Given this list of marker genes OR8H2, TAAR6, OR4F21, OR13C5, OR6C6, OR8D2, OR1G1, GPR151, OR10Q1, OR8B4, OR3A1, OR5P3, OR7D4, OR2L3 (NCBI Gene Id 81468), OR52B4, MTNR1B, OR6T1, OR51T1, OR2M4 (olfactory receptor family 2 subfamily M member 4), OR4D11, F2R, TAS2R19, OR4K5, MAS1L, ADGRB2, OR52E8, MC4R, ADGRD1, SLC39A9, OR52H1, GHSR, TPRA1, OR2C3, OR10A3, OR2M3, FFAR3, P2RY8, OR10C1, GPR149, GPR34, OR2T11 (olfactory receptor family 2 subfamily T member 11), TRHR, MRGPRX4, P2RY2, OR5I1, CHRM3, LPAR4, DRD5, ADGRG3, NMBR, OR2T6, ADRA2A, OR4M2, OR56B2P, ADGRL4, TAS2R7, OR51J1, OR51G1, GPR139, GPR183, LANCL1, RAMP1, GABRB1, OR2T12, OR6N1, SPHK1, OR11L1, OR6J1, OR5AC2, OR8K5, OR2A14, GPR143, CCR1, OR2AJ1, OR10X1, OR2M2, GPR26, TAAR2, OR4D5, GRM7, NPY2R, OR52A4P, CRHR1, OR52N2, TAS2R39, OR6N2, OR2G3, ADRA2C, SORCS3, OR5H14, OR8D1, OR56A3, OR51G2, OR9Q2, OR6F1, ELOVL4, OR7A17 (olfactory receptor family 7 subfamily A member 17), OR6X1, MLNR, OR5H1, OR6C70, ADGRA2, ADGRF2P, OR4D6, GPR3, OR10AC1, OR10T2, VIPR2, OR4L1, OR4A8, OR3A2, OR10H2 (NCBI Gene Id 26538), OR4E2, OR5M9, AGTR1, NLRP6, PTGER2, OR2T10, GPER1, AVPR1A, OR14A2, OR2A5 (olfactory receptor family 2 subfamily A member 5), GPR142, OR8D4, OR5T3, ADRB2, OR5D18, FZD3 (frizzled class receptor 3), OR2A1, OR5AK3P, CHRM1, OR10A6, OR6B2, NMUR2, OR2T33, GPRC6A, GPR157, MRGPRX1, TAS2R50, GPR182, OR1E1, CXCR4, HCAR3, PTGDR2, ADGRB1, GRPR, EDNRA, S1PR2, OR4Q3, OR8B2, SORCS2, OR4C11, OR5A1, GRIK3, OR10W1, OR4A16, OR51H1, ACKR1, OR5AK2, OR11H1, OR2G6, CCR3, PTGER4, AGTR2, OR7G1, DRD2, UTS2R, OR10D3, OR6C1, CASR, OR11H4, OR5AL1, S1PR4, GPR132, OR52L2P (NCBI Gene Id 79274), OPRK1, FBXW7-AS1, GPRC5A, OR2B2, OR4M2B, ADGRG5, OR5H6, OR5B21, GPR65, MRGPRD, CXCR6 (C-X-C motif chemokine receptor 6), OR1N2, OR2AG1, OR5K1, CYSLTR1, PPARG, OR51S1, OR10G4, OR2AT4, OR5C1, OR10A2, MCHR2, GPR20, CHRM2, OR6C3, OR1N1, OR51Q1, ADGRG4, OR10G2, OR6B1 (NCBI Gene Id 393045), LGR4, OR4S1, OR10AD1, OR5B2, SPHK2, OR6K6, FZD5, OXER1, S1PR5, OR5T1, OR11H12, OR52N4, OR11G2, OR51B5, OR4D9, S1PR3, OR12D2, FPR1, OR56A4, GNRHR, OR52E5, ADGRF4, OR4P4, F2RL1, OR5H8, OR2T35, OR10J6P (olfactory receptor family 10 subfamily J member 6 pseudogene), OR52E6, OPN1SW, GNRHR2, GNAT2, MRGPRE, OR13G1, GRM1, ADRB1, HTR5A, ADRA1B, NMUR1, GRM8, GPR135, RAMP2, NPY4R, TAS1R3, GP1BA, OR2A25, RXFP3, OR2C1, P2RY14, GPR25, OR51M1, ADGRE1, OR2AP1, OR5AN1, OR7D2, OR9K2, OR4K15, OR4N4, GPR19, OR1A2, OR56B1, OR10A7, OR11H6, HTR7, OR8G5, FFAR4 (NCBI Gene Id 353126), ADGRE5, OR52I1, OR2A7, OR10G9, GPR174, OR14I1, SMO, OR3A3, ADRA1A, ACKR3, OR1J2, HTR2C, OR4K1, OR1M1, OR4K13, GRM3, OR2AG2, OR5AU1, OR8G3P, OR10P1, GPR85, OR1L8, AGTRAP, CXCR1, PTH1R, OR51D1, OR1K1, OR52E4, P2RY12, TAS2R42, GPR150, OR7C1, OR8B8, VN1R17P, OR52J3, OR1D5, OR4A47, ADGRD2, OR10H5, LPAR1 (NCBI Gene Id 1902), TAS2R3, ACKR2, OR1E3, FZD10, OR10J1, OR1J4, TAS2R38, OR5AC1, OR2A12, GALR3, GPR33, OR7A10, OR52W1, OR51A7 (olfactory receptor family 51 subfamily A member 7), F2RL3, FZD6, OR8G1, OR5T2, APLNR, OR12D1, CELSR2, OR1L4, OR2A2, ADGRL2, CNR2, RXFP4, ADGRG1, GPR179, CHRM5, OR52Z1P, LHCGR, GABBR2, OR2Z1, OR2L13, FPR3, OR52E1, TAAR3P, HCRTR1, P2RY10, GPR63, OR2T7, PRLHR, OR52E2, OR4F29, OR6P1, ADGRF1, OR52M1, HTR2B, GCGR, OR13C4, SSTR3, OR8A1, GPRC5B, GALR1, OR2W3, CCR10, RXFP2, ADORA2A, P2RY11, OR51A4, OR4F3, OR1D4, OR2F1, ADORA1, TAS2R45 (taste 2 receptor member 45), OR4D1, OR4F15, OR51E2, OR11H2, GPR146, OR7A2P, OR10V1, FFAR2, ADORA2B, TAS2R41, LGR5, NPY4R2, GRM4, CXCR3, LGR6, LPAR6 (lysophosphatidic acid receptor 6), GPR176, OR14J1, OR2D3, OR4X2, OR10K1, OR8I2, OR2T4, OR52R1, ADRB3, CCR2, RHO, CELSR3, NPY6R, ADRA2B, SSTR5, OR10G7, HCAR2, HTR1A, LTB4R2, GPR199P, SSTR4, GPR141, OR1B1, CALCR, P2RY4, GPR39 (NCBI Gene Id 2863, G protein-coupled receptor 39), OR1P1, ADGRA1, TACR3, OR5A2, OR8J2, NPY5R, INPP5K, MC5R, OR4Q2 (olfactory receptor family 4 subfamily Q member 2 (gene/pseudogene)), OR52L1, MRGPRX3, OR51B6, OR2F2, OR9A4, DRD1, OR52B6, HTR6, CRCP, OR2J1, OR4A5, OR2K2, OR4D10, GPR161, OR8H3, CCKBR, NPR1, SIGMAR1, ADORA3, OR51V1, TBXA2R, OR5B12, GPR27, FZD2, FZD1, CNR1, OR14C36, OR8B3, OR13C8, HRH3, FZD7 (frizzled class receptor 7), OR6B3, GPR83, OR4K2, OR4F16, OR10S1, HCRTR2, OR8U9, OPRD1, GRM5, OR11A1, GPR31, GPR78, OR1F12P (olfactory receptor family 1 subfamily F member 12, pseudogene), OR8H1, P2RY6, NPY1R, ADGRL3, GPR119, OR10G3, PAX8, OR8S1, NPFFR1, OR1F2P (olfactory receptor family 1 subfamily F member 2 pseudogene), OR9G1, OR9A2, HTR4, MTNR1A, OR8U3, OR5M8, GPR171, HRH4, OR10G6, ADGRE2 (adhesion G protein-coupled receptor E2, NCBI Gene Id 30817), GRM6, OR4C12, TAS2R9, OR6Q1, TAS2R16, HTR1E, OXTR, SUCNR1, OR56A5, GPR35, OR4K17, TAS2R60, OR5P2, OR1S2, OR4F5, OR9A1P, OPN3, NPY, OR6K3, OR2S2, OR1J1, OR2Y1, PTGER1, TAS2R5, OR10J4 (olfactory receptor family 10 subfamily J member 4 (gene/pseudogene)), OR1L1, OR5L1, OR8B12, TAPT1 (transmembrane anterior posterior transformation 1), CCR6, AVPR1B, OR2T2, OR13H1, GPRC5C, P2RY13, OR5H15, PTAFR, OR2A4, CCR8, OR13F1, OR6C68, ADGRG7, MRGPRG, TAAR8, OR2B3, CHRM4, OR10Z1, C3AR1, OR5M10, GPR32, OR51I1, OR13C6P, GLP2R, OR4N5, OR7G2, C5AR2 (NCBI Gene Id 55868, complement C5a receptor 2), OR4A15, TAS2R13, OR2B6, OR52P1, GABBR1, OR4C16, GPR15 (NCBI Gene Id 2838), FSHR, OPN1MW3, CALCRL, OR6A2, GPR75, OR4F4, ADGRG6, OPN1LW, NTSR2, HCAR1, OR2B8P, GPBAR1, OR4A4P, RORB, OR11H7, TAS2R30, GPR22, OR2T27, OR10D4P, OR2H2, CCR7, OR13A1, OR7E24, GPR162, ADGRG2, OR5B17, NPBWR2, OR5V1, GPR153, GRID1, OR4E1, OR8J1, OR9G9, GPR101, OR13C3, OR56B4, OR2T5, TAAR1, GPR84, GPR45 (G protein-coupled receptor 45), OR8U8, OR2L5, GPR156, ADRA1D (NCBI Gene Id 149), PTGDR, OR52N5, OR6V1, HTR2A, OR4C45, OR2A42, SSTR1, CXCR5, GPR50, FZD4, OR7C2, OR6C4, HTR1F, CELSR1, GPRC5D, OPN1MW, NTSR1 (neurotensin receptor 1), OR6C75, MCHR1, GPR158, OR52D1, GALR2, TAS2R43, NPSR1, OR51L1, HRH2, DRD4, TSHR, OR4C15, PDGFRB, CCR5, OR2M7, OR5BS1P (NCBI Gene Id 390313), SCTR, OR2L2, OR5AR1, GPR68, RXFP1, TAS1R1, OR8J3 (NCBI Gene Id 81168), FZD8, OR1A1, OR2W6P, OR52I2, OR8K1, LPAR2, GPR37L1, RAMP3, OR6Y1, CRHR2, MRGPRX2, OR2B11, HPGD, OR7G3, OR2V1, OR10K2, OR10H1, NPR3, OR12D3, FZD9, OR10J5, F2RL2, OR51A2, CCR4, MC3R (melanocortin 3 receptor), OR14K1, OR2T3, GPR87, GPR55, OR4C46, TAS2R31, OR5AP2, OR2V2, OR5K4, OR10H4, KCTD16, HRH1, OR2AE1, OPN4, OR6C76, PTGFR, VIPR1 (vasoactive intestinal peptide receptor 1), OPRM1, GPR62, OR10AG1, OR5M11, OR7A5, OR14L1, BRS3, TAS2R40, OR2T34, GPR32P1, PROKR1, OR51C1P, OR5B3, ADCYAP1R1, LPAR5, VN1R5, OR5M3, OPRL1, OR10H3, OR4F6, TAAR9, BDKRB2 (NCBI Gene Id 624), GPR148, OR10R2, OR5D14, OR10G8, OR5F1, TAS2R1, GRM2, EDNRB, OR6C74, GPR61, OR52K2, CCR9, OR2L8 (NCBI Gene Id 81463), OR2T1, GPR82, OR4C6, OR4C3, OR13C9, PTGIR, GPR17, OR4C13, ADGRF5, VN1R1, OR1L3, OR1F1, NPFFR2, OR1S1, RRH, TAS2R4, OR5H2, OR4F17, OPN1MW2, OR4S2, ACKR4, PTH2R, GAL, GPR42, OR4B1, CXCR2, CMKLR1, ZNF219, OR5K2, GPR37, OR2M5, PDGFRL, OR9G4, TAS2R46, SORCS1, OR5L2, GPR21, OR52A1, OR9Q1, OR14A16, OR2J2, OR5D16, OR4M1 (olfactory receptor family 4 subfamily M member 1), OR2D2, ADGRV1, TAS2R10, TAS1R2, AVPR2, TACR2, OR52B2, SSTR2, GPR18, OR5G3, OR4N2, CX3CR1, TAAR5, ADGRA3, OR13D1, OR2W5P, OR56A1, ADGRL1, TACR1, OR10A5, GPR4, TAS2R14, GPR152, OR2G2, OR1Q1, OR5D13, OR2J3, KISS1R, OR52N1, ADGRF3, OR5AS1, OR8G2P, OR4D2, OR8U1, OR13J1, GPR88, FFAR1, OR51F2, OR1E2, TM2D1, OR5J2, OR6C65, GLP1R, HTR1D, OR6S1, OR5M1, GPR160, OR2W1, GPR52, OR2T29, GPR6, FPR2, OXGR1, CCRL2, P2RY1, MRGPRF, OR52K1, OR4K14, OR51F1, S1PR1, MC1R, OR8K3, OR6M1, XCR1, VN1R3, OPN5, GHRHR, OR51E1, CYSLTR2, CMKLR2, BDKRB1, OR6C2, GIPR, OR10A4, ADGRB3 (NCBI Gene Id 9664), RGR, OR51I2, OR4C5, LPAR3, OR51B2, OR6K2, OR5W2, OR2AK2, PTGER3, OR1C1, OR4K3 (NCBI Gene Id 79539), GPR12, OR13C2, TAS2R20 (NCBI Gene Id 266660), OR2T8, OR52A5, OR5K3, GPR173, TAS2R8, PROKR2, QRFPR, OR51B4 (olfactory receptor family 51 subfamily B member 4), NPBWR1, VN1R2, CCKAR, OR9I1, OR1I1, OR2H1, ADGRE3, HTR1B, MC2R, LTB4R, OR4X1, DRD3, MAS1, C5AR1, OR10J3, OR2I1P, VN1R4, OR13C7, OR1D2, OR1L6, here is a description of the gene set: Combining with an extracellular signal and transmitting the signal across the membrane by activating an associated G-protein; promotes the exchange of GDP for GTP on the alpha subunit of a heterotrimeric G-protein complex. studied in species Homo sapiens Human Gene Set: GOMF_G_PROTEIN_COUPLED_RECEPTOR_ACTIVITY